Given this list of marker genes Pcna, Nrm, Suv39h1, Narf, Lmnb2, Eif6, Nup35, Emd, Stx1b, Lmnb1, Hlcs, Prr14, Lmna, Lbr, Lmntd2, Cask, Rnf220, here is a description of the gene set: studied in species Mus musculus Mouse Gene Set: GOCC_NUCLEAR_LAMINA The fibrous, electron-dense layer lying on the nucleoplasmic side of the inner membrane of a cell nucleus, composed of lamin filaments. The polypeptides of the lamina are thought to be concerned in the dissolution of the nuclear envelope and its re-formation during mitosis. The lamina is composed of lamin A and lamin C filaments cross-linked into an orthogonal lattice, which is attached via lamin B to the inner nuclear membrane through interactions with a lamin B receptor, an IFAP, in the membrane.